Given this list of marker genes Il6 (interleukin 6), Sdc2, Megf6, Ahsg, Igfbp5, Apol7e, Amelx, Afp, Vcan, Cp, Serpina1c, F5, Qsox1, C3, Pappa2, Pdia6, Ltbp1, Enam, Serpina1b, Alb, Vwa1, Ktn1, Apol7c, Mbtps1, Tnc, Hrc, Chgb, Tgoln1, Prkcsh, Apoa5, Notum, Ambn, Gpc3, Gas6, Meltf, Pappa, Fuca2, Ano8, Serpind1, Apol9b, Apoa1 (NCBI Gene Id 11806), Ckap4, Lgals1, Apol11b, Stc2, Igfbp3, Igf2, Pnpla2, Igfbp6, Adam10, P4hb, Fbn1, Fstl1, App, Fgg, Apol10b, Aplp2, Men1, Apol9a, Igfbp2, Cdh2, Vgf, Scg3, Apol7a, Pcsk9, Fstl3, Tmem132a, Mfge8, Timp1, Igfbp7, Bmp15, Mxra8, Apol11a (apolipoprotein L 11a), Msln, Mepe, Bpifb2, Hsp90b1, Penk, Spp1, Golm1, Amtn, Wfs1, Trf, Apol7b, Matn3, Cst3, Serpina10, Igf1, Dmp1, Itih2, Mia3, Apoe, Fam20c, Fga, Apob, Spp2, Apol10a, Igfbp1, Mgat4a, Sparcl1, Rcn1 (reticulocalbin 1), Dnajc3, Scg2 (NCBI Gene Id 20254), Igfbp4, Serpinc1, Bmp4, Fam20a, C4b, Prss23, Fn1, Proc (protein C), Calu, Apoa2 (apolipoprotein A-II), Csf1, Apol8, Ccn1, Kng2, Nucb1, Fgf23, Shisa5, Chrdl1 (NCBI Gene Id 83453), here is a description of the gene set: Mouse Gene Set: REACTOME_REGULATION_OF_INSULIN_LIKE_GROWTH_FACTOR_IGF_TRANSPORT_AND_UPTAKE_BY_INSULIN_LIKE_GROWTH_FACTOR_BINDING_PROTEINS_IGFBPS Regulation of Insulin-like Growth Factor (IGF) transport and uptake by Insulin-like Growth Factor Binding Proteins (IGFBPs) species: Mus musculus